The following is a description of a gene set: studied in species Homo sapiens A process in which membrane potential cycles through a depolarizing spike, triggered in response to depolarization above some threshold, followed by repolarization. This cycle is driven by the flow of ions through various voltage gated channels with different thresholds and ion specificities. Human Gene Set: GOBP_ACTION_POTENTIAL, and this is the list of marker genes: SCN4B, ADRA1A (adrenoceptor alpha 1A), CACNA1G, KCNG4, TRPM4, KCNE3, SCN3A, NPS, GNA11, ABCC8, FLNA, CAMK2D, AKAP7, TRPA1, KCND2, MIR133A1, DLG1, KCNC1, KCNV2, SCN1A, KCNG2, RNF207, HCN4, SCN4A, KCNV1, KCNS1 (potassium voltage-gated channel modifier subfamily S member 1), DRD1, TBX18, GPR88, NEDD4L, KCNB1, TNF, SLMAP, KCNS3, ATP1B1, JUP, FGF12, KCNK2, GJA1, BBS10, PTPN3, GBA1, CNTNAP1, USP53, HCN3, CALM1, KCNA7, CD36, KCNA2, CLCN2, SLC9A1, DMD, YWHAE, NTRK3, BIN1, CACNB4, GNA14, GPD1L, GRIK2, HCN1 (hyperpolarization activated cyclic nucleotide gated potassium channel 1), CALM3, TACR1, MYH14, KCNN2, KCNB2, FGF13, GJC1, SCN7A (sodium voltage-gated channel alpha subunit 7), KCND1, CACNA1I, GJD2, ATP1A2, SNTA1, KCNJ2, GPRIN3, CACNA1C, KCNMB2, NUP155, SLC4A3, KCNE2, NDP, RANGRF, CACNB2, YWHAH, AKAP9, ANK2, PKP2, SCN2B, SUMO1, KCNS2, NPR2, MIR1-1, KCNQ2, CACNB3, KCNJ11, KCNC3, CLN3, CASQ2, KCNK4, CAV1, CACNA2D1, CHRNB4, SLC8A1, SCN3B, TAC1, SCN11A, HCN2, KCNE4, TMEM161B, ATP2A2, KCNH2, SCN5A, SCN2A, CLCN1, DSC2, P2RX1, KCNA1, SCN1B, KCNJ5, MTOR, KCNK9, KCNMB3, SOD1, NRCAM, CLDN19, SCN10A, KCNA6, FKBP1B, CAV3, KCNF1, GRIA1, KCNJ3, CHRNB2, CHRNA1 (NCBI Gene Id 1134), KCNA3, GJA5, KCNIP2, KCNA4, KCNK3, GPER1, NOS1, CXADR, KCNK16, DSG2, FMR1, CACNA1D, CNR2, KCNA5, KCNC4, KCNG1, AKAP6, SCN8A, MIR208A (NCBI Gene Id 406990), MIR328, KCNC2, KCNG3 (NCBI Gene Id 170850), CHRNA4, GLRA1, CTNNA3, ANK3, KCNE1, RYR2, KCNH6 (NCBI Gene Id 81033), KCND3, ABCC9, KCNJ8, KCNMB4, SCN9A, KCNA10, ATP1A1, NOS1AP, KCNE5, NTRK2, KCNQ3, DSP, KCNQ1, MTNR1B, SLC8A2, ASIC5 (NCBI Gene Id 51802)